The following is a description of a gene set: Increased susceptibility to mycobacterial infections, as manifested by recurrent episodes of mycobacterial infection. species: Homo sapiens Recurrent mycobacterial infections Human Gene Set: HP_RECURRENT_MYCOBACTERIAL_INFECTIONS, and this is the list of marker genes: NEK10, DNAJB13, ODAD4, CYBB, IFNGR1, IRF1, DNAAF4 (NCBI Gene Id 1867), NFKBIA, DNAL1, DNAH11, STAT1, RSPH9, ZAP70, NME8, DNAH5, IKBKG, CCDC39, DNAI1, SPEF2, DNAH1, RPGR, ODAD3, ODAD1, ODAD2, DNAAF2, RSPH3, FOXJ1, DNAAF11, DNAH9, HYDIN, CFAP221, DRC1, GAS2L2, CFAP300, CCNO, DNAI2 (dynein axonemal intermediate chain 2), CFAP74, DCLRE1C, MCIDAS, GATA2, STK36, CFAP298, ISG15, TYK2, DNAAF1, RSPH4A, IL12RB1, CCDC40, NME5, DNAAF5, DNAAF3, LRRC56, ZMYND10, RSPH1, OFD1, SPAG1, TTC12 (NCBI Gene Id 54970), IFNGR2, DNAAF6